The following is a description of a gene set: Oxidation by cytochrome P450 Human Gene Set: WP_OXIDATION_BY_CYTOCHROME_P450 species: Homo sapiens, and this is the list of marker genes: CYP11B2, CYP2F1, CYP4X1, CYP4Z1, CYP4A11, CYP26A1, CYP8B1, CYP2A6, CYP4F2, CYP4F12, CYP2B6, CYP2D6, CYP3A7, CYB5R3, CYP27A1 (cytochrome P450 family 27 subfamily A member 1), CYP2C9, CYP2A7, CYP1A2, POR, CYP2R1, CYB5R4, CYP39A1, CYP24A1, CYP4F11, CYP3A5, CYP3A43, CYP27C1, CYP7A1, CYP11A1, CYP51A1, CYB5B, CYP2C8, CYP2W1, CYP26B1, CYP11B1, CYP26C1, CYP1A1, CYP2G1P, CYP1B1, CYP2U1, CYB5R2, CYP2S1 (NCBI Gene Id 29785), CYP2E1, CYP4B1, CYP20A1, CYP4F3 (cytochrome P450 family 4 subfamily F member 3), CYP4V2, CYP2J2, CYP27B1, CYP17A1, CYB5R1, CYP4F8, CYP4F22, CYP3A4, CYB5A, CYP2A13, CYP2C19, CYP7B1, CYP19A1, CYP2C18, CYP46A1, CYP4A22